The following is a description of a gene set: Genes for which mutations result in atrial septation defects, a major class of congenital heart disease. Congenital heart disease is the leading cause of infant morbidity in the Western world, but only in the past ten years has its aetiology been understood. Recent studies have uncovered the genetic basis for some common forms of the disease and provide new insight into how the heart develops and how dysregulation of heart development leads to disease. from publication Bruneau BG (PMID 18288184) species: Homo sapiens Human Gene Set: BRUNEAU_SEPTATION_ATRIAL, and this is the list of marker genes: TBX5, NKX2-5, MYH6, GATA4, TBX20